The following is a description of a gene set: from publication Wang W, Wyckoff JB, Goswami S, Wang Y, Sidani M, Segall JE, Condeelis JS (PMID 17440055) studied in species Mus musculus Human Gene Set: WANG_TUMOR_INVASIVENESS_DN Correlating tumor cell behavior in vivo with patterns of gene expression has led to new insights into the microenvironment of tumor cells in the primary tumor. Until now, these studies have been done with cell line-derived tumors. In the current study, we have analyzed, in polyoma middle T oncogene (PyMT)-derived mammary tumors, tumor cell behavior and gene expression patterns of the invasive subpopulation of tumor cells by multiphoton-based intravital imaging and microarray-based expression profiling, respectively. Our results indicate that the patterns of cell behavior that contribute to invasion and metastasis in the PyMT tumor are similar to those seen previously in rat MTLn3 cell line-derived mammary tumors. The invasive tumor cells collected from PyMT mouse mammary tumors, like their counterparts from rat xenograft mammary tumors, are a population that is relatively nondividing and nonapoptotic but chemotherapy resistant and chemotactic. Changes in the expression of genes that occur uniquely in the invasive subpopulation of tumor cells in the PyMT mammary tumors that fall on the Arp2/3 complex, capping protein and cofilin pathways show a pattern like that seen previously in invasive tumor cells from the MTLn3 cell line-derived tumors. These changes predict an enhanced activity of the cofilin pathway, and this was confirmed in isolated invasive PyMT tumor cells. We conclude that changes in gene expression and their related changes in cell behavior, which were identified in the invasive tumor cells of cell line-derived tumors, are conserved in the invasive tumor cells of PyMT-derived mouse mammary tumors, although these tumor types have different genetic origins. Down-regulated genes in the subpopulation of invasive PyMT cells (breast cancer) compared to the general population of PyMT cells., and this is the list of marker genes: DHX15, ESD, TPM3, TMED5, SIRT3, ATP6V1A, MSN, IVNS1ABP, B4GALT1, NSD3, SNHG7, TCF7L2, WDR26, GNB1, DNASE2, ANGEL2, GTF3C4, ATP6V1B2, MYADM, TCF25, IL17F, DLGAP5, COL6A1, CDC123, TTBK2, NUFIP2, CALR4P, JMJD6, PKP3, MPV17, MRPL38, ZC3H7A (zinc finger CCCH-type containing 7A), ID2, YWHAQ, RPL3, BUD31, EFNA5, UBE2H, RYK, CCNG1, VAMP3, MARCKS, TGFBR3, PRKCD, RLIM, WDFY1, NOMO1, VAPA, GM2A, DEGS1, MYC, BNIP3L, BTG1, HNRNPH2 (heterogeneous nuclear ribonucleoprotein H2), DLG1, ABCG1, ANKRD13A, DARS1, KARS1, ABCD4, LPAR1, INSIG2, PPP2R5C, ENO3, ANXA4, CD53, CACYBP, B2M, SLC50A1, CD9, MAP3K1, CEBPA (CCAAT enhancer binding protein alpha), RAB11B (RAB11B, member RAS oncogene family), SCYL1, RBM5, TGOLN2, HABP4, LIMD1, EIF3G, EEF1A1, MSANTD1, PSMB1, LCP1, TMEM254, CNBP, NHERF1, GNAI2, MFNG, RNF31, BIRC6, TBC1D10A, H1-0, DHRS3, ARF1, MDFIC, PEX19, PLAA, STK39, ESYT1, PPP1R7, TGFB1I1 (NCBI Gene Id 94988), SMG7 (SMG7 nonsense mediated mRNA decay factor), XDH, TSPYL1, RAD21, SLC27A1, DPH6, EMD, PPP1R12A, AEBP2, CCL3, PBXIP1, PTGES3, PCNP, CLK1, ATP1B1, MRPL19, CD44, MRTFB, STX8, ARVCF, KLHL9, AJUBA, MYL4, UBE2C, PPP1CB, CSAD, FURIN, RHAG, APLP2, SPINDOC, ISG20L2, ERGIC2, RNF4, CTNND1, CYTH3, RACGAP1, IQGAP1, NAA35, SKP1, NPC1, ITM2B, UHRF1, EXO1, GDI2, RANGAP1, BTG2, VBP1, PML, TFB2M, IGFBP5, CORO1C, COMMD10, SPP1, ILF3, PHTF2, ATF4, CSF2RB, YME1L1, SFPQ, RPL7L1, TCEA1, IGF2BP1, DYNC1LI2, SEC61A1, PTX3, NRAS, CINP, ECI1, ATRN, AP2A2, RPL29, NIPSNAP2, CDH1, MIA3, CPOX, GSK3B, SRRM1, UBE2L3, RBPJ (NCBI Gene Id 51580), METTL26, SS18L2, CANX, PDE6D, RSRP1, KBTBD2, CCNI, WDR1, YWHAZ, HSD17B10 (NCBI Gene Id 50828), IL16, TRAP1, IRAK1, LITAF, MYSM1, UGDH, ERBB3, ACTR2, WNT4, PPP2R2D, CP, POLR1B, NFIB, RAD1 (NCBI Gene Id 5810), CELF2, SPIN1, MYEF2, LY6E, FSTL1 (NCBI Gene Id 65385), LUC7L3, TTC3